The following is a description of a gene set: Transcriptional profiling of two isogenic models of transformation identifies a gene signature linking cancer with inflammatory and metabolic diseases. In accord with this common transcriptional program, many drugs used for treatment of diabetes and cardiovascular diseases inhibit transformation and tumor growth. Unexpectedly, lipid metabolism genes are important for transformation and are upregulated in cancer tissues. As in atherosclerosis, oxidized LDL and its receptor OLR1 activate the inflammatory pathway through NF-kappaB, leading to transformation. OLR1 is important for maintaining the transformed state in developmentally diverse cancer cell lines and for tumor growth, suggesting a molecular connection between cancer and atherosclerosis. We suggest that the interplay between this common transcriptional program and cell-type-specific factors gives rise to phenotypically disparate human diseases. studied in species Homo sapiens Human Gene Set: HIRSCH_CELLULAR_TRANSFORMATION_SIGNATURE_DN Down-regulated genes in the cancer gene signature, representing a gene signature of cellular transformation. from publication Hirsch HA, Iliopoulos D, Joshi A, Zhang Y, Jaeger SA, Bulyk M, Tsichlis PN, Shirley Liu X, Struhl K (PMID 20385360), and this is the list of marker genes: PARN, MYH10, NPM1, HEXIM1, ADGRA3, CENPF, DENR, ATP1B3, COMMD8, FBLN1, DPM3, C1orf216, BCLAF1, ADI1, S100A1, RAMP1, PLS3, PTDSS1, RAP2A, PRKACB, SPRY2, DDX46 (DEAD-box helicase 46), SYNCRIP, PTMS, MLLT11, SCHIP1, PCMT1, ANAPC15, RACGAP1, GALNT7, TTC3, CAVIN1, RUSC1, COL4A6, ZWINT (NCBI Gene Id 11130), DPYSL2 (NCBI Gene Id 1808), COTL1 (coactosin like F-actin binding protein 1), TSPAN14, DMD, SPARC, MPC1, HMGN3, DST, HACD2, ATP10D, TCEAL1, TNS3, MAMLD1, CHD9, GBP1 (guanylate binding protein 1), CCND3, GCAT (glycine C-acetyltransferase), UBP1, TPM2, SPATS2L, MRPL20, CRIM1, SRSF6, RGS20, SLCO2A1, TCF4, EPS8, TGFB2, PTPRK, THBS1, NAV2, ZMIZ1, BAG1, IFIT5, DKK1 (NCBI Gene Id 22943), ARHGEF17, SRRT, HARS1, KIF4A, SRSF2, NR2F2, CRYBG1, DROSHA, KANK2, GAS2L1, ADIRF (adipogenesis regulatory factor), LASP1, SFRP1, CAV1, DCAF6, PDLIM4, ASF1A, TOB1, ISOC2, DLG5, HTRA1, STARD7, ARHGDIB, KIAA0930, CALD1, AP5M1, DSTN (NCBI Gene Id 11034), ALCAM, NFIC, WDR73, NQO1, BLTP2